The following is a description of a gene set: Human Gene Set: GOCC_U6_SNRNP studied in species Homo sapiens A ribonucleoprotein complex that contains small nuclear RNA U6, the Lsm2-8 heptameric ring complex, as well as several proteins that are unique to the U6 snRNP, most of which remain associated with the U6 snRNA both while the U6 snRNP is free or assembled into the U4/U6 snRNP or into a series of spliceosomal complexes., and this is the list of marker genes: LSM6, RNU6-7, LSM7, LSM3, LSM4, LSM5, DDX39B, RNU6-1, LSM2, LSM8, RNU6-9